The following is a description of a gene set: from publication Fujisaki H, Kakuda H, Shimasaki N, Imai C, Ma J, Lockey T, Eldridge P, Leung WH, Campana D (PMID 19383914) Human Gene Set: GSE12198_LOW_IL2_STIM_NK_CELL_VS_HIGH_IL2_STIM_NK_CELL_DN Transcriptional profiling of NKAES-derived NK cells after 7 days of culture compared to primary human NK cells and NK cells stimulated by low or high dose IL2 after 7 days of culture. Genes down-regulated in NK cells: low dose versus high dose of IL2. species: Homo sapiens, and this is the list of marker genes: MRPL15, IL17RB, CHRM4, CAPZB, DHH, LCT, SLC9B2, DUSP14 (NCBI Gene Id 116242), GJA3, FMO2, TNNC2, ADAM21, OPRL1, RRAD, CACNB4 (NCBI Gene Id 785), TMEM41B, RRH, PDIA3, POLA1, REG3G, CLDN16, TLR9, SMIM8, KLK4 (NCBI Gene Id 9622), DIAPH1, KLRC3, SLAIN1 (NCBI Gene Id 122060), DHX57, C9orf72, ASPM, LAT, SPR, STK10, ART4, KDM7A, SLC7A2, CLVS1, AOAH, MTF2, NKX3-2, PAX6, SLCO6A1, AVPR1A, METTL6, C4orf19, SDHAF4, MTERF4, LTO1, SEPHS1, B3GNT2, FOXA3, YWHAG, KRT32, IDI1, USP43, KDF1, RGS1, PDE6H, JMY, CER1, ARRB2, PLIN4, VCAM1, PLA2G2F, VPS13C, WRN, TMEM9B, FGR, SCN5A, ITGB5, ATP6V1C1, CD44, CGA, PCDHB11, SPRR3, USP11, DHX16, KRTAP4-12, TMPRSS11D, RIN1, CDKN2A, TTC8 (tetratricopeptide repeat domain 8), MAP3K4, PI16, ACOT13, GNB4, ABAT, GNB3, NT5C3A, SEL1L3, KCNK1, NUP88, ATG13, CELF1, VASN, NPY (NCBI Gene Id 4852), SLC35A5, MAP1LC3A, IQCC, SLC4A7, CAMK2D, AGR2, NEK2, MYO1E, CENPC, SFXN3, CLEC11A, EPB41L1, GRIN2D, WDPCP, DRD3, CA6, ABHD8, MED28, WNT2, TMOD3, CDX2, TUBB4A, DLX3, LYZL4, TMOD1, SLC16A7, HGFAC, TOMM70, USP27X, CRADD, PPM1A, SYT12, STIM1, GPX7, DNAJB4, LCP2, KRT36, IL16, ZNHIT1, KRT8, SYNGR1, STAP2, ASTN1, ENPP3, R3HCC1, GCM1, CHST1, LAMTOR4, LTA, CIB1, COQ9, MRAP, ZBTB7B, LRRC46 (NCBI Gene Id 90506), PEA15, VPS41, PHF8, UGT2B10, TRIM10 (NCBI Gene Id 95309), DONSON, SC5D, DOCK2, FOXRED1, GPCPD1, TSPAN17, TSSK2, SASS6, MXD4, NAA60, MYO1H, USP24, CTSK, SPG11, FGF13, PHLDA1, EVA1C, NAB2, NR6A1, MTTP, PLPPR4, CHGB, CRIP1, CHIC1, BTG4, PIGR, WNT3, USP22, OR5D18, CSRP1, SEPTIN10, SMAD9, COL20A1, GPLD1, PLA1A, PBX1 (PBX homeobox 1), RUNX1T1, NCOA6, SP3, TAF6, CES3, MSGN1, COL9A1, DOCK1, NDUFS5